The following is a description of a gene set: Human Gene Set: HP_ABNORMAL_ANTIHELIX_MORPHOLOGY Abnormal antihelix morphology species: Homo sapiens An abnormality of the antihelix., and this is the list of marker genes: AP4E1, KAT6A, POR, BICRA, EYA1, RERE, SALL1, FOXG1, RAB3GAP1, MGAT2, SCNM1, AASS, RAB11B, LIG4, KAT6B, FLNA, RPL10, TCF3 (NCBI Gene Id 6929), FIG4 (FIG4 phosphoinositide 5-phosphatase), RNU4-2, PYCR2, GLI2 (NCBI Gene Id 50806), XYLT2, PIGN, CREBBP, KCTD1, STEEP1, WBP4, PAX1, TWIST1, PGAP1, FGFR3, RBM10, NUP188, FGFR2, WAC, EVC2, EFTUD2, EVC, TOR1A, RECQL4, RAB3GAP2, NSUN2, NR2F1, SLC16A2